The following is a description of a gene set: studied in species Mus musculus Golgi Associated Vesicle Biogenesis Mouse Gene Set: REACTOME_GOLGI_ASSOCIATED_VESICLE_BIOGENESIS, and this is the list of marker genes: Vamp2, Ap1b1, Ap1m2, Ap4b1, Igf2r, Snx5, Tfrc, Yipf6 (NCBI Gene Id 77929), Ap1g1, Clint1, Gak (NCBI Gene Id 231580), Tgoln1, Ap4e1, Sort1, Ap1s1, Cltc, Tpd52, Clta, Acbd3, Rab5c, Ap1s2, Cpd, Txndc5, Pik3c2a, Hip1r, Dnajc6, Sh3d19, Dnm2, Snx2, Hspa8, Bloc1s3, Vamp8, Bloc1s6, Arf1, Tpd52l1, Necap1, Arrb1, Ap3s1, Snx9, Pum1, Golgb1, Ocrl, Snapin, Ap3b1, Tbc1d8b, Ap1s3, Picalm, Fth1, Sh3gl2, Ftl2-ps, Bloc1s1, Bloc1s4, Napa, Ap1m1, Dtnbp1